The following is a description of a gene set: studied in species Mus musculus Any process that stops, prevents or reduces the frequency, rate or extent of membrane depolarization. Mouse Gene Set: GOBP_NEGATIVE_REGULATION_OF_MEMBRANE_DEPOLARIZATION, and this is the list of marker genes: Fzd9, Cav3, Got1, Hsh2d, Rbfox2, Alb, Bok, Src, Ngfr